The following is a description of a gene set: species: Mus musculus Any process that modulates the frequency, rate or extent of cardiac muscle cell proliferation. Mouse Gene Set: GOBP_REGULATION_OF_CARDIAC_MUSCLE_CELL_PROLIFERATION, and this is the list of marker genes: Rbp4, Mir133a-2, Vgll4, Wnt2, Ccnb1 (NCBI Gene Id 268697), Mapk11, Pim1, Apc, Foxp1, Tgfbr3, Yap1, Trp73, Mapk14, Fgf2, Mir1a-2, Nkx2-5, Tgfbr1, Ncam1, Bmpr1a, Notch1, Mef2c, Mir133a-1, Hey2, Tbx1, Kcnk2, Fgf20, Fgf9, Ccnd2, Pten, Zfpm2, Hdac2, Cited2, Jarid2, Cxadr, Tbx5, Tbx20, Bmp10, Nrg1, Fgfr2, Dyrk1a, Gja1, Rbpj, Tgfbr2, Cdk1, Gata6, Mapk1, Tbx2, Gata4, Erbb4, Nog (NCBI Gene Id 18121), Gli1 (NCBI Gene Id 22705), Sav1, Fgfr1